The following is a description of a gene set: from publication Chen Y, Wang X (PMID 31504780) Mouse Gene Set: MIR_7016_5P Genes predicted to be targets of miRBase v22 microRNA mmu_miR_7016_5p in miRDB v6.0 with MirTarget v4 prediction scores > 80 (high confidence targets). species: Mus musculus, and this is the list of marker genes: Nova2, Zfp444, Mtcl2, Ranbp10, Selenom, Xylb, Leng8, Chd3, Fign, Lhpp, Cyyr1, Psd4, Bzw1, Mxd4, Trim58, Klc2, Eif4e1b, Dop1a, Mpig6b, Bhlhe40, Trp53inp2, Nfat5, Rab11fip5, Klhl4, Rnf152, Ephb1, Pkd1, Aif1l, Gpr173, Arnt2, Hoxc10, Smap2, Htt, Clec16a, Sema6a (sema domain, transmembrane domain (TM), and cytoplasmic domain, (semaphorin) 6A), Baz2a, Slc1a3, Dmtn, Uqcrq, Zfhx3, Rassf2, Arhgdia, Fosl2, Ttc28, Nes, Mospd3, Ubqln2, Mea1, Rpl31, Aspg, Kcne1, Erv3, Idi2, Ap2a1, Zfp92, Dlk1, Galnt17, Avpr2, Pakap, Plxna4, Klhl9, Zfp641, Shisa7, Pak1ip1, Bahd1, Tmem175, Taok3, Sf3b4, Wdtc1, Mon1b, Lrrtm1, Zfp59, Dnal1, Kcnj10, Bard1, Ctnnd1, Ptpn3, Pianp, Slc7a8, Smarcc1, Gnat1, Ccbe1, Lrrc59, Ankrd63, Emc4, Prcp, Nos2, Lpar2, Rnf150, Matcap1, Drc7, Rin1, St3gal1, Dhtkd1, Itga8 (NCBI Gene Id 98963), Tspan9, Sash1, Ap1g1, Chst2, AI837181, Acad9 (NCBI Gene Id 67022), Aoc3, Rnd1, Morc4, Astn2, Ccdc171, C2cd2l, Mylk4, Tlcd5, Kics2, Wnt1, Ap1s3, Ipmk, Slc8a2, Zmat3, Zfp395, Klk4, Samhd1, Msl1, Rftn2, Nectin1, Slc16a14, Prdm2, AU018091, Cts8, Eya3